Given this list of marker genes GC, ABCC5, SLC52A2, SLC23A2 (solute carrier family 23 member 2), SLC22A2, CD320, SLC19A4P (NCBI Gene Id 56918), SLC2A14, SLC44A4, ABCG2, SLC19A3, SLC47A1, SLC25A19 (solute carrier family 25 member 19), SLC2A4, TTPA, FOLR3, SLC22A1, STRA6, SLC23A1, SLC2A1, SLC52A1, SLC22A14, SLC46A1, RTBDN, SLC2A7, SLC2A6, SLC49A4, SLC2A5, SLC2A2, RBP4, LRP2, SLC19A2, SLC52A3, SLC5A6, SLC2A8, SLC2A3, SLC27A1, AFM, TCN2, NPC1L1, SLC19A1, SLC35F3, TCN1, SLC2A10, SCARB1, CBLIF, AMN, SLC2A9, SLC25A32, FOLR2, CUBN, SLC2A11, ABCD4, SELENON, PDPN, APOA1, FOLR1, ABCC1, here is a description of the gene set: species: Homo sapiens The directed movement of vitamins into, out of or within a cell, or between cells, by means of some agent such as a transporter or pore. A vitamin is one of a number of unrelated organic substances that occur in many foods in small amounts and that are necessary in trace amounts for the normal metabolic functioning of the body. Human Gene Set: GOBP_VITAMIN_TRANSPORT